The following is a description of a gene set: species: Homo sapiens Human Gene Set: KEGG_MEDICUS_REFERENCE_HEME_BIOSYNTHESIS Heme biosynthesis. Pathway ID: N00601. Pathway type: Reference. Pathway class: nt06011 Heme biosynthesis. Pathway Definition from KEGG: Gly -- ALAS1/2 >> ALAD >> HMBS >> UROS >> UROD >> CPOX >> PPOX >> FECH -> Heme, and this is the list of marker genes: HMBS, UROD, FECH, ALAS1, CPOX, UROS, PPOX, ALAS2, ALAD